The following is a description of a gene set: The series of molecular signals mediated by the endoplasmic reticulum stress sensor IRE1 (Inositol-requiring transmembrane kinase/endonuclease). Begins with activation of IRE1 in response to endoplasmic reticulum (ER) stress, and ends with regulation of a downstream cellular process, e.g. transcription. One target of activated IRE1 is the transcription factor HAC1 in yeast, or XBP1 in mammals; IRE1 cleaves an intron of a mRNA coding for HAC1/XBP1 to generate an activated HAC1/XBP1 transcription factor, which controls the up regulation of UPR-related genes. At least in mammals, IRE1 can also signal through additional intracellular pathways including JNK and NF-kappaB. Mouse Gene Set: GOBP_IRE1_MEDIATED_UNFOLDED_PROTEIN_RESPONSE species: Mus musculus, and this is the list of marker genes: Dnajb9, Ufl1, Ern1, Agr2, Ddrgk1, Vapb, Parp16, Ptpn1, Ern2 (endoplasmic reticulum to nucleus signalling 2), Cops5, Hspa5, Tmem33 (transmembrane protein 33), Bfar, Pdia6, Ficd, Dnajc10